The following is a description of a gene set: species: Homo sapiens A type of retinal detachment arising due to a combination of contracting retinal membranes, abnormal vitreoretinal adhesions, and vitreous changes. It is usually seen in the context of diseases that induce a fibrovascular response, e.g. diabetes. Human Gene Set: HP_TRACTIONAL_RETINAL_DETACHMENT Tractional retinal detachment, and this is the list of marker genes: LRP5, NDP, ZNF408, TSPAN12, ATOH7, VCAN, CTNNB1, FZD4